Given this list of marker genes RPS7P11, CCDC43, ITGA2B, MBTD1, ENSG00000278774 (NCBI Gene Id 124904146), ARL4D, ARL17A, SPATA32, PHOSPHO1, PYY, MIR6165, TMEM92, SAMD14, MIR196A1 (NCBI Gene Id 406972), KRT19, RNU6-406P, PTGES3L, WIPF2, ENSG00000200538, MIR10A, KRTAP4-5, KRTAP4-11, SPOP, PTP4A2P1, DHX58, BECN1, HOXB1, MAP3K14-AS1, RETREG3, KPNB1, SKAP1-AS1, PRAC1, MIR6782, SP6, PLEKHH3, KRT39, CACNA1G, KRT41P, CALCOCO2, RNU1-42P, ENSG00000275219, LINC03057, JUP (junction plakoglobin), KRT24, NXPH3, LINC02075, HOXB-AS2, HOXB13, PRAC2, KRTAP9-6, HOXB-AS1, NFE2L1, PDK2, KRT35, B4GALNT2, HCRT, KRT33B, RNU6-453P, PNPO, SKAP1-AS2, G6PC1, PPY, NKIRAS2, SPATA20, MIR6783, GJD3-AS1, RDM1P2, RN7SL270P, ENSG00000273709 (NCBI Gene Id 124904136), COL1A1, RNU2-4P (NCBI Gene Id 26853), RAMP2 (receptor activity modifying protein 2), LINC00974 (long intergenic non-protein coding RNA 974), RPL29P31 (ribosomal protein L29 pseudogene 31), MIR6884, MRPL10, RNA5SP441, ENSG00000297729, KAT2A, TBC1D3P7, FAM187A, CDC27, ZNF652-AS1, KRT12, KRT17 (keratin 17), XYLT2, ACLY, RNU7-97P (RNA, U7 small nuclear 97 pseudogene), ETV4, IGF2BP1, MED24, KANSL1-AS1 (NCBI Gene Id 644246), NME1, AARSD1, RN7SL507P, RNU7-186P, ZPBP2, MIR6129, MIR2117HG, ENSG00000212565, GNGT2, TBX21, PTGES3L-AARSD1, ENSG00000212149, PSMC3IP, SRP14P3, KRTAP9-9, LINC00910, TOB1-AS1 (TOB1 antisense RNA 1), RPRML, CAVIN1, MAP3K14, ENSG00000278591, LRRC3C, MEOX1, ATP5MC1, LRRC46, KRTAP4-8, RNU6-470P, LRRC37A4P, KRTAP4-7, MIR4315-1, HMGN2P15, LINC02086, KRTAP9-12P, ENSG00000234859, ENSG00000266088, KRT222, ENSG00000294414, TBKBP1, OSBPL7, KRTAP1-4, KRTAP9-11P, KRT38, CRHR1, KRT33A (keratin 33A), RDM1P1 (NCBI Gene Id 112577465), KRTAP9-7, LRRC37A, MAPK8IP1P2, PRR15L, KRTAP4-9, KRT223P, CACNA1G-AS1, HEXIM2, FAM215B, RN7SL819P, EZH1, LSM12, COX6B1P2, COPZ2, RNU6-287P, WNT3, RN7SL405P, DLX4, NME1-NME2, EFCAB13, NT5C3B, HSD17B1P1, MIR8059, FLJ40194 (NCBI Gene Id 124871), RUNDC3A, RPL9P28, KRTAP3-3, MIR6866, G6PC3, KRTAP4-6, RAB5C, RNU6ATAC3P, EFCAB13-DT, ZNF385C (zinc finger protein 385C), DCAKD, NSF, KPNB1-DT (KPNB1 divergent transcript), RAB5C-AS1 (RAB5C antisense RNA 1), ITGB3, AOC4P, GAST, HOXB-AS4, CNP, MIR5089, ENSG00000278048, LINC01180, RNU6-826P, BRCA1P1, KRTAP3-4P, COA3, CNTD1, RPL5P33, GSDMA, ENSG00000267288, RARA-AS1, ATXN7L3-AS1, KRT25, MIR5010, ENSG00000251239, EPN3, ENSG00000275616, RPL6P26, NAGLU, CCDC200, VPS25, ACSF2, CASC3, RNU6-1313P, PLCD3, LRRC37A2, RAMP2-AS1, NSFP1, KIF18B-DT, NBR2, KRTAP29-1, ODAD4, SP2 (NCBI Gene Id 96833), KRTAP9-2, KRT15, RNU6-971P, KRTAP1-3, MAPT, KRT36, RUNDC3A-AS1, STAT5A, RSAD1, HAP1 (NCBI Gene Id 9001), ENSG00000267638, KRT42P, IKZF3, HOXB6, SPAG9, MIR6510 (microRNA 6510), KRTAP3-2, MIR548AT, MPP3, CSF3, ENSG00000297935 (novel transcript, antisense to PPP1R9B), MPP2, ZNF652, ENSG00000274432, SGCA, KRTAP9-10P, FKBP10, KRTAP4-16, KRTAP4-12, KRTAP4-17P, MEIOC, MRPS21P9, UBTF, FMNL1-DT, SP2-AS1, ACBD4, KRT20 (NCBI Gene Id 54474), KRTAP2-1, HOXB7, SOST, EIF1, RAPGEFL1 (Rap guanine nucleotide exchange factor like 1), NR1D1, KRT31, NAGS, CNTNAP1, KRT10, LINC02210, GPATCH8, KRT34, KRT9, KIF18B, DNAJC7, RN7SL258P, HDAC5, KRT37, RPL27, KRT28, KRTAP3-1, ENSG00000274862, LINC02073, CCR7, NMT1, TUBG1, COASY, UBE2Z, SHC1P2, MAPT-AS1, ADAM11, KRTAP9-4, KRTAP1-5, PLEKHM1, ENSG00000294490, RN7SL199P, KRTAP9-1, KRT26, CDK5RAP3, IFI35, HOXB9, TOB1, SLC35B1 (NCBI Gene Id 10237), TILAM, KRTAP9-3, NFE2L1-DT, GJD3, PPIAP54, CDC6, KRTAP4-3, PHB1 (NCBI Gene Id 5245), HIGD1B, KRTAP16-1, KRT224P, RND2, GJC1, TAC4, GFAP, HEXIM2-AS1, ORMDL3, RNU6-131P, FMNL1, RNA5SP442, SNX11, STAT3, HOXB-AS3, ENSG00000305838, FZD2, KLHL10, KRTAP2-2, ASB16, SUMO2P7, LINC01976, ABI3, STAT5B, RNU6-1152P, KRT40, VAT1, HOXB8, HSD17B1, TMEM101, RPS26P8, PPP1R9B, EFCAB15P, CHAD, TOP2A, KRT32, ARL17B, C1QL1, TMEM92-AS1, LINC02071, WFIKKN2, KRTAP2-4, RNU2-1, ENSG00000250282, UTP18, ENSG00000288961, DND1P1, GIP, P3H4, TNS4, KRTAP4-2, MIR6867, CBX1, TUBG2, MIR1203, TMEM106A, ENSG00000238804, MIR152, KRTAP1-1, ARHGAP27, KRT27, DUSP3, PICART1, SPPL2C, MSL1, ENSG00000250286, MAPT-IT1, NME2, GHDC, HOXB5, ATP6V0A1, MLX, MYL4, SKAP1, ANKRD40, KRT16, MRPL27, ENSG00000277903, LINC02594, RPL21P4, RARA, ASB16-AS1, NBR1, STH, SCRN2, CFAP97D1, ITGA3, HOXB2, SNORD124, CCR10, HROB, SMCO4P1, RPL7P48, AOC2, FAM215A, NPEPPS, KAT7, CD300LG, AOC3, ABCC3, MRPL45P2, WNK4, HSD17B1-AS1, ENSG00000276596, MIR2117 (microRNA 2117), SMARCE1, SLC25A39, ENSG00000265547, ATXN7L3, RNU2-32P, DBF4B, GSDMB, ENSG00000274452, LUC7L3, WHSC1L2P, PSMD3, GOSR2, CCDC103, LINC00671, KANSL1, RPL23AP75, HEXIM1, EFTUD2, MYCBPAP, SUMO2P17, LRRC37A17P, THRA (NCBI Gene Id 7067), KRT10-AS1, KRT23, EME1, EIF4EP2, GRN, RN7SL399P, RNU6-1201P, TMUB2, FAM171A2, HMGB3P27, HOXB4, SNF8, LINC02210-CRHR1, KLHL11, MIR3185, C17orf113 (NCBI Gene Id 110806298), WNT9B, DHX8 (DEAH-box helicase 8), B4GALNT2P1, KRTAP9-8, FMNL1-AS1, LRRC59, ENSG00000274062, TTLL6, HOXB3 (homeobox B3), NGFR-AS1, MIR6780A, FAM117A, KCNH4, BRCA1, MAPK8IP1P1, RUNDC1, RN7SL125P, RNA5SP443, KRT43P, NGFR (NCBI Gene Id 4804, nerve growth factor receptor), KRTAP17-1, KRT14, H1-9P, KRT8P34, IGFBP4, KRTAP4-4, RN7SL656P, RNU6-1137P, KRT13, RPL7L1P5, DLX3, MIR6781, PSME3, ATP5MGP7, MIR6784, KRTAP2-5P, ANKRD40CL, KRTAP4-1, KRTAP2-3, SLC4A1, GOSR2-DT, HSPB9, here is a description of the gene set: Human Gene Set: chr17q21 species: Homo sapiens